Given this list of marker genes Araf, Snx1, Atg7, Slc6a15, Cdc16, B020004C17Rik, Col19a1, Sema3a, Dusp22, Chrnb4, Zfp811, Aoah, Dbi, Shprh, Slain1, Tbc1d20, Arid1a, Clec2g, Bnip3l, Adss2, Lyrm4, Sp3, Tox3, Aplp2, Cdc40, Mnat1, Dus4l, Lcorl, Elf5, Hcn1, Nebl, Nrg4, Rufy2, Elmod2, Kcnj1, Zfp39, Bicd1, Zfp352 (NCBI Gene Id 236537), Tlk2, here is a description of the gene set: from publication Chen Y, Wang X (PMID 31504780) Mouse Gene Set: MIR_6932_5P Genes predicted to be targets of miRBase v22 microRNA mmu_miR_6932_5p in miRDB v6.0 with MirTarget v4 prediction scores > 80 (high confidence targets). species: Mus musculus